The following is a description of a gene set: Human Gene Set: HP_DOLICHOCEPHALY studied in species Homo sapiens An abnormality of skull shape characterized by a increased anterior-posterior diameter, i.e., an increased antero-posterior dimension of the skull. Cephalic index less than 76%. Alternatively, an apparently increased antero-posterior length of the head compared to width. Often due to premature closure of the sagittal suture. Dolichocephaly, and this is the list of marker genes: CUL7, AKT1, JAG1, BGN, ERI1, TWIST1, IFT43, ADH5, NELFA, WDR19, SLX4, SKI, RAB39B, KDM5B (lysine demethylase 5B), MAD2L2, PEX2, SNAP29, PTH1R, CNTN1, ASH1L, RELN, ATP6V0A2, BLM, ARCN1, INTS1, SCARF2, AHDC1, PEX16, SOX6, SCNM1, IL6ST, NEDD4L, CNOT3, ARSB, KRAS, OBSL1, SLC3A1, CEP57, SMAD3, OFD1, TBX5, UBE2T, GDF1, FANCD2, ALG14, VAC14, SMAD2 (NCBI Gene Id 654050), PEX13, HGSNAT, ITCH, DIS3L2, SPTBN1, CILK1, PEX14, COL25A1, CNTNAP1, TRAIP, GATA4, DPH2, MADD, PEX1, FANCG, ERGIC1, PTEN, ZNF142 (zinc finger protein 142), MVK, NPR2, HNRNPK, TMEM53, PEX19, CHRNG, COL5A1, FANCA, ALPL (NCBI Gene Id 249), TFAP2A, RNU4ATAC, GATA5, RNU4-2, KATNB1, NOTCH3, VDR, NDE1, NAA20, PCDHGC4, KMT2D, MN1 (MN1 proto-oncogene, transcriptional regulator), SCO2, BRCA1, MKRN3, PEX26, BICRA, IL11RA, CDC42BPB, BRCA2, APC2, ERMARD, EBF3, GATA6, FGFR2, FANCF (FA complementation group F), HERC2, KMT2E, IFT122, KIF15, RYR1, SCYL2, TMEM216, MYH3, GLI3, NPAP1 (NCBI Gene Id 23742), WDR35, CITED2, SHANK3, LTBP4, FANCM, FANCB, CPLX1, RFWD3, PWRN1, RUSC2 (NCBI Gene Id 9853), RAF1, TRIM37, IFT81, SCN4A, NFIX, KCNH1, RAD51C, MTM1, NOTCH2, FGF9, KDM6B, IFT52, FBN2, ASXL3, DYM, NSD1, SNORD116-1, EXTL3, TRIP12, DLX3, NSD2, FANCE (NCBI Gene Id 2178), PSMC1, ZFPM2, THUMPD1, RPL10, SLC35D1, MSL3, PEX10, TGFB3, NKX2-5, NKX2-6, PALB2, KCNJ2, IFT140, FANCC, FANCI, LETM1, PEX5, GNB2, BRIP1, DHCR24, KCNK9, AGO2 (argonaute RISC catalytic component 2), ATRX (NCBI Gene Id 6475), MAGEL2, IPO8, RHOBTB2, PEX12, RFX7, PEX6, FANCL, FLT4, CTBP1, SLC6A9, DPH1, PEX3, PRPS1, TBX1, MAN1B1, KPTN, PPP2R5D, KMT2A, ALX4, HSD17B4, SNORD115-1 (NCBI Gene Id 338433), KDR, PREPL, ATP6V1B2, SUPT16H, IDS, PIGG, ORC4, TBC1D7, FBN1, PWAR1, H3-3B, CCDC8, ERF, FKTN, INPPL1, FIG4, DMXL2, RAD51, IDUA, KCNJ5, BRAF, YY1, PI4KA, GJA5, XRCC2, PEX11B, MGAT2, GCSH, EXOC6B, TGFB2, PRIM1, ERCC4